The following is a description of a gene set: Human Gene Set: HP_GENERALIZED_TONIC_SEIZURE A generalized tonic seizure is a type of generalized motor seizure characterized by bilateral limb stiffening or elevation, often with neck stiffening without a subsequent clonic phase. The tonic activity can be a sustained abnormal posture, either in extension or flexion, sometimes accompanied by tremor of the extremities. studied in species Homo sapiens Generalized tonic seizure, and this is the list of marker genes: NEUROD2, GRM7, PAFAH1B1, SLC6A19, KCNQ2, MAPK10, CDKL5, KCNT1, SCN8A, PIGA, SLC25A22, GNAO1, DMXL2, NECAP1, DOCK7, CACNB4, PRRT2, PIGP, SCN9A, COG2, SLC32A1, EEF1A2 (eukaryotic translation elongation factor 1 alpha 2), PIGT, SLC1A2, MDH2, VPS50, RPL10, STXBP1, KCNA1, DPM1, DNM1, GNB1, SCN1B, GRIN2A, CACNA1A, TANGO2, PNKP, SCN1A, CASK, GRIN1, KARS1, PACS2, SIK1, CUX2, TUBA1A, ADGRV1, GABRA1, CPLX1, SCN2A, GABRG2, KCNQ3, COQ8A, SATB1, GABRB3, ARX, CHD2, ARHGEF9, CTCF, TBCD, HCN2, PIGQ (NCBI Gene Id 9091), LONP1, TRIM8, PCDH19